Given this list of marker genes PPOX, POLD1 (NCBI Gene Id 5424), GPR35, SMPD1, CASP10, GPC4, CTNNB1, UROD, CREBBP, CEL, RTL1, ABCB11, SLC2A2, SEMA4A, HBB, IL12RB1, SMARCB1, KCNQ1OT1, AHCY, APC, SETBP1, CC2D2A, ATP7B, PHKG2, KCNJ11, TULP3, GNAS, SOX4, SKIC2, HNF4A, STAT6, CPOX, SLC37A4, NAB2, SMARCE1, SMARCD1, PMS2, PDE11A, ATM, PALLD, IRF5, HMBS, HFE, F5 (coagulation factor V), TMEM67, KRAS, WT1, INS, BTK, CCND1, ASL, ZFX, MUTYH, APPL1, GCK, PMS1, POU6F2, G6PC1, TRIP13, TP53, IL12A, MST1, NEUROD1, JAK2, SMAD4, PHKA2, SMARCC2, SKIC3, TJP2, TNPO3, PIK3CA, REST, PHKB, HNF1A, ABCC8, FAH, CASP8, ARID1B, TNFSF15, PDX1, BRCA2, KLF11, SPIB, SMARCA4, BMP6, PRKAR1A, ARID1A, FAS, PKHD1, FASLG, SOX11, BLK, RPGRIP1L, SLC25A13, PYGL, BMPR1A, PALB2, GIMAP5, BRCA1, ARID2, DIS3L2, ABCB4, IGF2R, PAX4, POU2AF1, PDGFRL, INPP5E, MSH6, MEG3, SERPINA1, GPC3, CDKN1C, VHL, TCF4, POLE, KCNQ1, RPS20, SEMA4D, DPF2, IGF2, MPV17, CDKN2A, TGFBR2, EP300, MET, MMEL1, SPRTN, DLK1, H19, RABL3, CHEK2, ZFTA, MSH2, JAG1, TRIM28, DZIP1L, AXIN1, MLH1, BMP2, EPCAM (NCBI Gene Id 4275), here is a description of the gene set: species: Homo sapiens Human Gene Set: HP_NEOPLASM_OF_THE_LIVER Neoplasm of the liver A tumor (abnormal growth of tissue) of the liver.